The following is a description of a gene set: Mouse Gene Set: GOMF_ALPHA_TUBULIN_BINDING Binding to the microtubule constituent protein alpha-tubulin. studied in species Mus musculus, and this is the list of marker genes: Eml4, Slc6a2, Ttll7, Fnta, Hdac6, Fam110c, Trpv4, Dlec1, Washc1, Spmip6, Dnai7, Wipf3, Spast (NCBI Gene Id 54171), Sncg, Lrrc61, B4galt1, Efhc1, Pacrg, Ncald, Gja6, Dnal1, Sncb, Snca, Tbcb, Setd2, Bex6, Hsph1, Dip2b, Cav3, Taok1, Gnas, Tbce, Ino80, Tbcel, Bex4, Gja1, Bbs4, Racgap1, Dysf, Ppargc1a, Ndel1, Fyn, Arl8b, Arl4c (ADP-ribosylation factor-like 4C), Trim36, Trappc14, Enkd1, Ofd1